The following is a description of a gene set: Human Gene Set: GSE40184_HEALTHY_VS_HCV_INFECTED_DONOR_PBMC_UP studied in species Homo sapiens This study characterizes the effects of chronic Hepatitis C virus (HCV) infection on gene expression by analyzing blood samples from 10 treatment-naive HCV patients and 6 healthy volunteers. Differential expression analysis of microarray data from peripheral blood mononuclear cells (PBMCs) identified a 136 gene signature, including genes elevated in infected individuals. Most of the up-regulated genes were associated with interferon (IFN) activity (including members of the OAS and MX families, ISG15 and IRF7), suggesting an ongoing immune response. This HCV signature was also found to be consistently enriched in many other viral infection and vaccination datasets. Validation of these genes was carried out using a second cohort composed of 5 HCV patients and 5 healthy volunteers, confirming the up-regulation of the IFN signature. In summary, this is the first study to directly compare blood transcriptional profiles from HCV patients with healthy controls. The results show that chronic HCV infection has a pronounced effect on gene expression in PBMCs of infected individuals, and significantly elevates the expression of a subset of interferon-stimulated genes. Genes up-regulated in peripheral blood monocytes (PBMC): healthy donors versus patients with HCV infection. from publication Bolen CR, Robek MD, Brodsky L, Schulz V, Lim JK, Taylor MW, Kleinstein SH (PMID 23067362), and this is the list of marker genes: ZNF280B, HSD3B1, RIMOC1, MDN1, PFKM, ABL2, MOB4, ARHGAP28, NUDT11, LACTB, SIGLEC7, HOXA1, NINJ2, IL10RA, KCNA5, BARHL1, KCNC2, PURG, LMBRD1, MAPK8, C18orf54 (chromosome 18 open reading frame 54), WEE2, WDR46, IFNGR2, CXCR5, GGA2, CXXC5, POLE3, SH2D1A, RRN3, PDS5B, MEOX1, GRM4, PRF1, ROGDI, TSC22D3, EGFR, TNFRSF11A, CCNT1, IGFBP6, PTCH2, ZNF23, MST1R, MARCHF7, TMEM65, NXPE4, TRIM35, AK3, CPLX2, DYNC2I2, SIM1 (NCBI Gene Id 6492), GPRC5A, TMEM102, NSG2, SVIL, ABAT, CD33, OVGP1, LACTB2, WNT6, ZNF518B, PTPN12, ZC4H2, ABHD17B, DIPK1A, NMNAT3, POGK, MCEMP1, DVL2, NOCT, HTR1D, TUBB2A, HACD3, SLFN12, GRHL1, COL2A1, CYP2C18, SNHG32, AFF3, EHHADH, ZMYM3, FGF13, BAZ2B, TTC13, RHBDD2, GPR158, CMPK2, GADD45A, EOMES, TPP1, MTFR1, GANC, MCRIP2, ARMT1, NOBOX, CAPN6, ZFP41, TBC1D4, SCPEP1, ADH4, CLYBL, SLAIN1, SLC22A4 (NCBI Gene Id 6583), TSN, RPS6KA6, ANKRD39, GPR155, KRT80, CTTNBP2, ZNF354C, MESP2, TMEM191C, MTFMT, AHR, PHAF1, CDC14B, PLCB1 (NCBI Gene Id 23236), SNX33 (NCBI Gene Id 257364), EPAS1, ALOX5, EPB42, INTS9, CEP95, ACTG2 (NCBI Gene Id 72), NOP2, SLC17A9, TMEM116, C5AR1, CYB5R3, FOXN2, ESM1, KLHDC2, SERPINA11, ZCCHC18, DZIP1L, RALYL, SLC6A18, TBC1D12, MTHFD1L, IRF7, FCRL1, KRTAP13-2, BTBD6, TAF1C (NCBI Gene Id 9013), TPCN2, TRPM7, RPL31, C11orf16, TMTC4, LRRK2, MIGA1, KRAS, GPR137B, POU6F1, F2RL1, ADK, S1PR1, ZNF623, MUTYH, ARL5B, ATF4, FGFRL1, IL5, SP6, CLK2, NARS2, HOXA5, XRCC2, MAT2A, SNCA, TNFAIP6, CC2D2A, HPCAL1 (hippocalcin like 1), DPP4, HEY1, MAST1, FLCN, P2RX4, IFT88, NR4A2, KPNA4, GPR39, USP34, STEAP1, TCN2 (transcobalamin 2), SRSF1, ILKAP, ORC4, NEIL1, EPN2, MAGED2 (MAGE family member D2), ALOX12, RASA3, TMEM216, C10orf90, FAM171B, RNF145, TOMM20, RAB3C